The following is a description of a gene set: Genes expressed at higher levels in rostral regions beginning in the subventricular zone, in some cases extending into the intermediate zone and cortical plate of embryonic day 14.5 mouse cortex. studied in species Mus musculus from publication Bedogni F, Hevner RF (PMID 34321999) Mouse Gene Set: HEVNER_CORTEX_ROSTRAL_SUBVENTRICULAR_ZONE, and this is the list of marker genes: Sema5a, Eomes, Robo2, Pde1c, Sema3c, Afap1, Prex1, Tspan7, Satb2, Cdh8, Plxna4